Given this list of marker genes Umps, Mtor, Dhodh, Cmpk1, Cad, Cps1, here is a description of the gene set: The chemical reactions and pathways resulting in the formation of pyrimidine nucleobases, 1,3-diazine, organic nitrogenous bases, beginning with the synthesis of a pyrimidine ring from simpler precursors. Mouse Gene Set: GOBP_DE_NOVO_PYRIMIDINE_NUCLEOBASE_BIOSYNTHETIC_PROCESS species: Mus musculus